Given this list of marker genes NSD1, DMTN, PDCD10 (NCBI Gene Id 9226), STK4, CNOT9, CREBL2, PFN2, RAF1, MAD2L2, EGFR, IL11, PAQR3, IRGM, LIF, NT5DC2, ARAF, IL6, NLRP2B, TENM1, ERCC6, BRAF, GADD45A, STOX1, PTEN, CNKSR3, RASSF2, OSM, IFNG, AKT1, SPRY2, TRIM6, here is a description of the gene set: Any process that modulates the frequency, rate or extent of the phosphorylation of peptidyl-serine. Human Gene Set: GOBP_REGULATION_OF_PEPTIDYL_SERINE_PHOSPHORYLATION studied in species Homo sapiens